Given this list of marker genes LHFPL4, HRAS, LGI1, OGT, NETO2, C1QL2, TRAF6, KIF2C, GPC6, GPC4, DLG1, GHSR, OLFM1, DAG1, DLG4, CACNG2, EPB41L3, GPHN, ERBB4, CACNG7, VPS26B, GPSM2, GIT1, CACNA2D2, CNIH3, RAP1A, IQSEC2, MAP2K1, CACNG3, ERBB2, VWC2, NPTX1, RAPSN, ADAM10, C1QL3 (complement C1q like 3), NETO1, GABARAP, TMEM108, here is a description of the gene set: studied in species Homo sapiens A process in which a neurotransmitter is transported to, or maintained in, a location within the membrane adjacent to a postsynaptic specialization (e.g. postsynaptic density). Human Gene Set: GOBP_NEUROTRANSMITTER_RECEPTOR_LOCALIZATION_TO_POSTSYNAPTIC_SPECIALIZATION_MEMBRANE